Given this list of marker genes IGKV3-20, IGHV4-34, IGLV1-47, CRP, MASP2, IGKV2-28, IGLV1-51, IGHV2-5, MASP1, IGHV2-70, IGKV1D-39, IGLV3-21, IGKV5-2, C1QC, IGKV3-11, FCN2, IGKV1D-16 (NCBI Gene Id 28901), IGLV2-14, IGHV1-46, IGHG2, IGKV3D-20, IGLV2-8 (immunoglobulin lambda variable 2-8), IGHV4-39, C1S, IGKV1-33, C1QA, IGHV1-2, IGHV3-23, IGHV3-48, FCN1 (NCBI Gene Id 2219), COLEC10, IGKV2D-30, C1R, IGKV2-30 (immunoglobulin kappa variable 2-30), IGKV1-39, IGKV1-12 (NCBI Gene Id 28940), IGLV3-25, COLEC11, IGLV2-23, IGKV1D-33, IGLV2-11, IGHV4-59, MBL2, IGHV3-30, IGLV7-43, IGHV1-69, FCN3, IGKV1D-12, IGHV3-13, IGLV1-40, IGHV3-11, C1QB, IGKV1-17, IGKV4-1, IGKV2D-28, IGLV3-19, IGKV1-5, IGHV3-33, IGKV2D-40, IGKV1-16, IGLV3-1, IGHV3-53, IGHG4, IGLC2, IGHV3-7, IGLV6-57, IGLV3-27, IGHG1, IGLC3, IGKV3-15 (immunoglobulin kappa variable 3-15), IGLV1-44, here is a description of the gene set: Creation of C4 and C2 activators studied in species Homo sapiens Human Gene Set: REACTOME_CREATION_OF_C4_AND_C2_ACTIVATORS